The following is a description of a gene set: Gene down-regulated by CD40 signaling in Ramos cells (EBV negative Burkitt lymphoma). Human Gene Set: BASSO_CD40_SIGNALING_DN from publication Basso K, Klein U, Niu H, Stolovitzky GA, Tu Y, Califano A, Cattoretti G, Dalla-Favera R (PMID 15331443) studied in species Homo sapiens Substantial evidence indicates that signaling through the CD40 receptor (CD40) is required for germinal center (GC) and memory B-cell formation. However, it is not fully understood at which stages of B-cell development the CD40 pathway is activated in vivo. To address this question, we induced CD40 signaling in human transformed GC B cells in vitro and identified a CD40 gene expression signature by DNA microarray analysis. This signature was then investigated in the gene expression profiles of normal B cells and found in pre- and post-GC B cells (naive and memory) but, surprisingly, not in GC B cells. This finding was validated in lymphoid tissues by showing that the nuclear factor-kappaB (NF-kappaB) transcription factors, which translocate to the nucleus upon CD40 stimulation, are retained in the cytoplasm in most GC B cells, indicating the absence of CD40 signaling. Nevertheless, a subset of centrocytes and B cells in the subepithelium showed nuclear staining of multiple NF-kappaB subunits, suggesting that a fraction of naive and memory B cells may be subject to CD40 signaling or to other signals that activate NF-kappaB. Together, these results show that GC expansion occurs in the absence of CD40 signaling, which may act only in the initial and final stages of the GC reaction., and this is the list of marker genes: TUBB2A, GSDME (gasdermin E), RASGRP2, BMP7, BORCS8-MEF2B, ITGB7, PNOC, GRAP, IGFBP6, TSPO, UBE2J1, BICD2, PTPN22, NINJ1, CTDSP2, RERE, AIF1, BIK, CRYZ, CD27, TTC9, ISG20, CNR1, PALM2AKAP2, POU2AF1, BTG2 (NCBI Gene Id 7832), CAMP, SYK, TRAC, ST3GAL6, CDH17, ID1, USP6, IRS1, ST6GAL1, CD38, ALDH5A1, LMO3, VNN2, JCHAIN, RAPGEF2, TMT1A, TRIB2, NCF1, CSF2RB, SH2B2, GPER1, SLC2A5, RUNX1T1, ORAI2, PRKAR2B, HDAC9, NPAS1, LTB, GCNT1, PTPN18, RIMS3, PTP4A2, RAPGEF5, ARHGEF18, RNF187, ID3, BCL6, TCF3, AQP3, NCF4, HMCES, BLNK (B cell linker), KCNN3, ARL4C, HSD17B8